Given this list of marker genes AGGF1, ACBD4 (NCBI Gene Id 79777), AKNA, PIK3R3, BMP2K, GDPD1, AMACR, MEIS1, DNAAF2, SOX7, C2orf68, FBXL15, HOXB3, BMP4, MYLIP, ZNF462, CCNF, HILPDA, HTT, THUMPD3, FANCF, CASP8, CSTF2T, RBM43, MECOM, DHX35, RUNX1T1, GATA6 (NCBI Gene Id 2627), MBLAC2, LIPT1, FZD2, PTCD2, HOXA3, FAM117B, PRMT6, TMEM50B, NREP, TNFRSF1B, RALGPS2, CH25H, PINX1, ZNF397, VWA5A (NCBI Gene Id 4013), FUT8-AS1, SNN, CMTM3, PATZ1, HEATR6, FBXO42, ELK3, SUOX, PALMD (NCBI Gene Id 93975), ZFP36L2, SIX5, KCNH7, NAPEPLD, GATA6-AS1, GPAM, ENSG00000240497, ATOH8, FAN1 (FANCD2 and FANCI associated nuclease 1), GSPT2, HOXA2, here is a description of the gene set: from publication Gargalovic PS, Imura M, Zhang B, Gharavi NM, Clark MJ, Pagnon J, Yang WP, He A, Truong A, Patel S, Nelson SF, Horvath S, Berliner JA, Kirchgessner TG, Lusis AJ (PMID 16912112) Genes from the blue module which are dn-regulated in HAEC cells (primary aortic endothelium) after exposure to the oxidized 1-palmitoyl-2-arachidonyl-sn-3-glycerophosphorylcholine (oxPAPC). Human Gene Set: GARGALOVIC_RESPONSE_TO_OXIDIZED_PHOSPHOLIPIDS_BLUE_DN Oxidized phospholipids are thought to promote atherogenesis by stimulating endothelial cells (ECs) to produce inflammatory cytokines, such as IL-8. In studies with mouse models, we previously demonstrated that genetic variation in inflammatory responses of endothelial cells to oxidized lipids contributes importantly to atherosclerosis susceptibility. We now show that similar variations occur in cultured aortic ECs derived from multiple heart transplant donors. These variations were stably maintained between passages and, thus, reflect either genetic or epigenetic regulatory differences. Expression array analysis of aortic EC cultures derived from 12 individuals revealed that >genes were regulated by oxidized phospholipids. We have used the observed variations in the sampled population to construct a gene coexpression network comprised of 15 modules of highly connected genes. We show that several identified modules are significantly enriched in genes for known pathways and confirm a module enriched for unfolded protein response (UPR) genes using siRNA and the UPR inducer tunicamycin. On the basis of the constructed network, we predicted that a gene of unknown function (MGC4504) present in the UPR module is a target for UPR transcriptional activator ATF4. Our data also indicate that IL-8 is present in the UPR module and is regulated, in part, by the UPR. We validate these by using siRNA. In conclusion, we show that interindividual variability can be used to group genes into pathways and predict gene-gene regulatory relationships, thus identifying targets potentially involved in susceptibility to common diseases such as atherosclerosis. studied in species Homo sapiens